Given this list of marker genes SLC1A5, RAMAC, OPRM1, SBF2, C1QTNF12, HRAS, here is a description of the gene set: species: Mus musculus Genes down-regulated in MEF cells (embryonic fibroblast) isolated from HRAS knockout mice. from publication Castellano E, De Las Rivas J, Guerrero C, Santos E (PMID 16909116) We characterized differential gene expression profiles of fibroblast cell lines harboring single or double-homozygous null mutations in H-ras and N-ras. Whereas the expression level of the individual H-, N- and K-ras genes appeared unaffected by the presence or absence of the other ras loci, significant differences were observed between the expression profiles of cells missing N-ras and/or H-ras. Absence of N-ras produced much stronger effects than absence of H-ras over the profile of the cellular transcriptome. N-ras(-/-) and H-ras(-/-) fibroblasts displayed rather antagonistic expression profiles and the transcriptome of H-ras(-/-) cells was significantly closer to that of wild-type fibroblasts than to that of N-ras(-/-) cells. Classifying all differentially expressed genes into functional categories suggested specific roles for H-Ras and N-Ras. It was particularly striking in N-ras(-/-) cells the upregulation of a remarkable number of immunity-related genes, as well as of several loci involved in apoptosis. Reverse-phase protein array assays demonstrated in the same N-ras(-/-) cells the overexpression and nuclear migration of tyrosine phosphorylated signal transducer and activator of transcription 1 (Stat1) which was concomitant with transcriptional activation mediated by interferon-stimulated response elements. Significantly enhanced numbers of apoptotic cells were also detected in cultures of N-ras(-/-) cells. Our data support the notion that different Ras isoforms play functionally distinct cellular roles and indicate that N-Ras is significantly involved in immune modulation/host defense and apoptotic responses. Human Gene Set: CASTELLANO_HRAS_TARGETS_DN